Given this list of marker genes AAAS, CDCA8, BIRC5, NDC1 (NDC1 transmembrane nucleoporin), NUP58, AURKA, NUP62, NUP54, INCENP, NUP133, SEH1L, NUP43, POM121C, RANBP2, UBE2I, NUP214, NUP188, PIAS4, NUP93, NUP35, RAE1, NUP153, SEC13, NUP155, PIAS3, NUP210, NUP88, NUP107, PCNA, NUP37, NUP85, NUP98, NUP205, TPR, NUP160, SUMO2, POM121, TOP2A (NCBI Gene Id 7153), SUMO1, SUMO3, NUP42, AURKB, TOP2B (DNA topoisomerase II beta), TOP1, NUP50, RANGAP1 (NCBI Gene Id 6381), here is a description of the gene set: The sliding clamp protein PCNA, Aurora-A, Aurora-B, Borealin, and various topoisomerases can be SUMOylated. SUMOylation of PCNA appears to reduce formation of double-strand breaks and inappropriate recombination. SUMOylation of Aurora-A, Aurora-B, and Borealin is necessary for proper chromosome segregation. SUMOylation of topoisomerases is observed in response to damage caused by inhibitors of topoisomerases. Reactome Pathway: SUMOylation of DNA replication proteins species: Homo sapiens part of: SUMO E3 ligases SUMOylate target proteins